Given this list of marker genes RBPJ, MAML3, HEY1, NOTCH2, RBPJL, NOTCH3, JAG1, MAML2, NOTCH1, MAML1, NOTCH4, HES1, here is a description of the gene set: Human Gene Set: KEGG_MEDICUS_PATHOGEN_HPV_E6_TO_NOTCH_SIGNALING_PATHWAY_N00380 HPV E6 to Notch signaling pathway. Pathway ID: N00380. Pathway type: Pathogen. Pathway class: nt06511 NOTCH signaling. species: Homo sapiens Pathway Definition from KEGG: E6 -> JAG1 -> NOTCH -> (NICD+RBPJ+MAML) => (HES1,HEY1)